The following is a description of a gene set: from publication Rubenstein AB, Smith GR, Raue U, Begue G, Minchev K, Ruf-Zamojski F, Nair VD, Wang X, Zhou L, Zaslavsky E, Trappe TA, Trappe S, Sealfon SC (PMID 31937892) Human Gene Set: RUBENSTEIN_SKELETAL_MUSCLE_ENDOTHELIAL_CELLS species: Homo sapiens, and this is the list of marker genes: HLA-DRA, ARHGAP29, EMCN, LGALS3, CLEC14A, COL4A2, CD36, IGF2 (NCBI Gene Id 492304), NRP1, ITGA6, CAVIN2, IFITM2, BTNL9, ENG, SYNE2, GIMAP4, IFITM3, MGLL, MYH9, SLC14A1, CDH5, FOXN3, TNFSF10, BST2, LPAR6, PHACTR2, ESAM, CA4, HSPB1, F8, DDX17, RGCC, MYL12A, FABP5, TXNIP, ADGRL4, HLA-E, ITGA1, CD34, C1orf54, PODXL, KIF25, SEC62, HLA-C, SRGN, FKBP1A, HMGB1, MMRN2, DPYSL2, KLF2, ETS1, TIMP3, NHERF2, EGFL7, LY6E, SPARCL1, MGST2, WSB1, CD93, PTPRB, TMEM88, MYCT1, AFDN, TM4SF18, SOX4, HLA-B, WARS1, FLT1, ISG15, CAV2, UACA, COL4A1, GIMAP7, ANXA3, VWF, PALMD, ADGRF5, TCF4, RAMP2, HLA-DRB1, RHOC, EPAS1, IFI27, HLA-DPA1, CAV1, ARGLU1 (arginine and glutamate rich 1), TMSB10, TACC1, PDLIM1, KLF6, CALM1, SEC14L1, POMP, MEF2C, LAP3, POLR2L, RDX, GNG11, CD74, FABP4, IL32, TMSB4X, AQP1, IGFBP4, ATP5PF, CRIP2, CD59, ID1, A2M, HLA-A, ARL6IP1, FMO2, PLS3, CLDN5, ICAM2, NEAT1, RNASE1, B2M, MYL12B, ID3, AHNAK, VAMP5, S100A16, PPIC, ABLIM3 (NCBI Gene Id 22885), STOM, MYL6, GNAI2, SPTBN1, NKTR, ITM2A, CCDC85B, HLA-DMA, HLA-DPB1, HSPG2, CAVIN1, TM4SF1